Given this list of marker genes PDE11A, MTNR1B, NHERF4, THBS1, PDE10A, PDE2A, here is a description of the gene set: studied in species Homo sapiens Any process that decreases the rate, frequency or extent of cGMP-mediated signaling. Human Gene Set: GOBP_NEGATIVE_REGULATION_OF_CGMP_MEDIATED_SIGNALING